Given this list of marker genes Thbs1, Cry1, Srebf2, Apoe, Agtr2, Itgb3, Irs2, Fis1, Adipoq, Shh, Kcnk9, Abca2, Atp5pf (NCBI Gene Id 11957), Cry2, Acacb, Igfbp3, Itgav, Nrg1, Acsl4, Akt2, Pla2r1, Akt1, Pla2g10, Ptpn11, Irak1 (NCBI Gene Id 16179), Nr1h2, Apoc2l, Nr1h3, Hbp1, Apoa2, Tspo, Nfkbia, Egf, Apoc3, Apoc2, Apoc1, Pcsk9, Hrh2, here is a description of the gene set: Mouse Gene Set: GOBP_NEGATIVE_REGULATION_OF_LIPID_TRANSPORT studied in species Mus musculus Any process that stops, prevents, or reduces the frequency, rate or extent of the directed movement of lipids into, out of or within a cell, or between cells, by means of some agent such as a transporter or pore.